The following is a description of a gene set: studied in species Mus musculus Mouse Gene Set: GOBP_NEGATIVE_REGULATION_OF_EXTRINSIC_APOPTOTIC_SIGNALING_PATHWAY Any process that stops, prevents or reduces the frequency, rate or extent of extrinsic apoptotic signaling pathway., and this is the list of marker genes: Faiml, Src, Tnfrsf22, Tnfsf4, Peli3, Map2k5, Bcl2l10, Hspa1b (heat shock protein 1B), Gdnf, Rb1cc1, Gstp3, Gas1, Eya4, Fgb, Faim, Hgf, Snai2, Rela, Icam1, Bmp4, Tmbim1, Cx3cl1, Gclm, Htt, Unc5b, Cttn, Fga, Eya3, Birc6, Bcl2, Eya1, Gstp2, Nrp1, Dab2, Eya2, Mcl1, Sgk3, Nrg1, Itgav, Fgf10, Ripk1, Hmox1, Fcmr, Acvr1, D1Pas1, Gfral, Mapk7, Lgals3, Tcf7l2, Stradb, Itprip, Park7, Gata1, Vegfa, Phip, Itga6, Grina, Lmna, Rnf34, Fgg, Il4, Gstp1, Col2a1, Igf1, Ddx3x, Klf4, Raf1, Nol3, Gclc, Hmgb2, Ar, Zmynd11, Rps6kb1, Sh3rf1, Tgfbr1, Fyn, Scg2, Agap2, Cflar, Brca1, Csf2, Il1b, Gsk3b, Tert, Pea15a, Gstp-ps, Pak5, Rffl, Siah2, Faim2, Il19, Tnfrsf4, Bcl2l1, Sfrp2, Prdx2, Tnfrsf23, Gpx1, Serpine1, Psme3, Tnfaip3, Il7, Yap1, Tnf, Ctnna1